The following is a description of a gene set: species: Homo sapiens Human Gene Set: chr5q15, and this is the list of marker genes: GGCTP1, RIOK2, NR2F1-AS1, PCSK1, RGMB-AS1, SKIC3, LINC01340, ENSG00000306172, NPM1P27, RPL7P18, CAST, LIX1-AS1, MTCO1P24, FAM81B, MIR583, MIR2277, CSNK1A1P3, POLD2P1, CTBP2P4 (NCBI Gene Id 649922), RNU1-73P, MTCYBP35, MCTP1, PSME2P1, RHOBTB3, MRPS35P2, RFESD, LINC01846, MTCO2P24, HSPD1P11, KRT8P32, SLF1, MTND5P12, RNU6-402P, ERAP2, ENSG00000286577, RNU6-308P, KIAA0825, SETP22, LIX1, NR2F1, RTRAFP2, LNPEP, YTHDF1P1, GPR150, MCTP1-AS1, LINC01554, RNU6-524P, RGMB, GLRX, POU5F2, MTCYBP40, ERAP1, FABP5P5 (fatty acid binding protein 5 pseudogene 5), ARSK, ELL2, SPATA9, ARB2A, DDX18P4, MTND6P3